The following is a description of a gene set: Human Gene Set: REACTOME_NEURONAL_SYSTEM Neuronal System species: Homo sapiens, and this is the list of marker genes: GLRA2, KCNMB1, EPB41L2, GABRR3, KCNJ14, SYT7, GNGT2, HTR3C, KCNK7, GABRA4, GABRB1, SLITRK2, CHRNA1, ADCY2 (NCBI Gene Id 254679), CHRNA3, GNB3, AKAP5, TUBB8B, RTN3, DNAJC5, KCNH3, LRRTM3, BCHE, GRIA4, EPB41L5, DLGAP4, CAMK1, GNG10, SLITRK5, GABRR1, KCND2, KCNV1, CAMK2A, RIMS1, GLRA1 (glycine receptor alpha 1), TSPAN7, GNAI3, GNG3, SYN1, GABRA2, KCNJ12, PRKAR1B, GNGT1 (G protein subunit gamma transducin 1), SHARPIN, GRIP2, KCNA5, GRIN2C, DLG1, CACNA1E, PRKAA2, CACNG3, KCNJ4, GABRB3, ABCC8, MAPK3, NRXN2, KCNJ6, EPB41, ACHE, LRRTM2, SLC1A7, MAOA, GJC1, KCNF1, ADCY1, PPFIBP2, LRRC4B, ADCY6, PPFIBP1, AP2B1, KCNK9, PLCB2, NLGN3, CAMK2B, CAMK2D, MAPT, PRKCG, BEGAIN, TUBA3C, SLC6A13, TSPOAP1, CAMKK2, NPTN, HCN1, SLC32A1, KCNH4, SYN2, SLC18A3, KCNA4, CHRNA7, KCNAB2 (NCBI Gene Id 8514), NSF, KCNA10, TUBB3, ERBB4, APBA1, GRIN2A (glutamate ionotropic receptor NMDA type subunit 2A), NBEA, RAC1, KCND1, GJD2, SHANK2 (NCBI Gene Id 654128), KCNB2, AP2M1, GRIN2D, HOMER3, KCNH5, NAAA, KCNJ10 (potassium inwardly rectifying channel subfamily J member 10), HCN3, AP2A1, GLUL, KCND3, TUBA3D, KCNH6, AP2S1, KCNQ1, SYT10, GNB4, DLG4, KIF17, CAMKK1, PPFIA4, GABBR1, KCNJ11, NLGN2, KCNMB4 (NCBI Gene Id 27345), AP2A2, COMT, GIT1, GLS2, RASGRF1, ARL6IP5, GNB2, PTPRF, NRXN3 (neurexin 3), TUBA1A, GLRB, KCNK1, EPB41L1, LRRC51, CASK, GRIK4, CACNB2, MAPK1, GABRA5, CHRNE, KCNAB3, GRIN3A, STX1A, RPS6KA2, SYN3 (synapsin III), SLC22A2, GABRG2, TUBA4A, KCNA7, KCNS1, GNG13, ADCY4, PRKAG2, ALDH2, DBNL (drebrin like), SLC6A1, KCNJ1, CACNG4 (calcium voltage-gated channel auxiliary subunit gamma 4), GABRB2, KCNK3, CACNG2, ALDH5A1, ADCY8, CHRNA2, CHRNB3, KCNJ8, CHRNB4, MDM2, CHRNA5, GJA10, KCNJ2, CALM1, DLG2, GRIN1, SLC6A3, DLGAP1, SLC1A2, SLITRK4, GAD1, KCNG1, KCNK4, PTPRD, KCNQ3, TUBA8, KCNH1, KCNN2, KCNC3, RPS6KA6, NRXN1, SLC1A6, KCNJ5, SYT1, DLG3, CACNA1B, PRKAA1, PRKAG1, SYT12, SHANK1, KCNB1, HOMER2, HOMER1, NCALD, VAMP2, KCNG4, KCNMB3, KCNC4, FLOT2, GNG8, KCNH8, SNAP25, KCNQ4, ABCC9, FLOT1 (flotillin 1), CHRNG, CREB1, LRRC7, NRAS, CHRNA6, LRRTM1, UNC13B, GNG7, SLC38A1, NLGN4X, PRKCB, HTR3A, SLC38A2, CACNA1A (NCBI Gene Id 773), NEFL, SLITRK6, PLCB1, GNG5, GABRA3, KCNJ9, KCNC1, SLC22A1, KCNK10, IL1RAPL1, GRIA1, KRAS, KCNK16, CHRNB2, GRIP1, RPS6KA1, HRAS, TUBA1B, PANX2, GABRG3, ADCY5, PTPRS, KCNMA1, HTR3B, ARHGEF7, GRM5, GABBR2, KCNAB1, RPS6KA3, KCNH7, SLC5A7, ADCY9, PICK1, KCNG3, KCNG2, KCNN4, TUBB4A, KCNQ2, PDPK1, SIPA1L1, ARHGEF9, LRTOMT, ABAT, DLGAP3, CHRND, APBA2 (NCBI Gene Id 9029), GRIK3, KCNJ16, TUBA3E, HCN4, TUBB2A, GABRQ, LRRTM4 (leucine rich repeat transmembrane neuronal 4), PRKACA, IL1RAP, MYO6, CAMK4, SLC6A11, PPM1F, KCNA3, LIN7C, GABRA6, PPM1E, KCNH2, TUBB8, SLC6A12 (NCBI Gene Id 6539), SLC1A3, HTR3E, SYT2, CACNA2D2, KPNA2, HTR3D, TUBB2B, GNAI1, GABRA1, PRKAB2, RAB3A, KCNJ3, KCNV2, GNG12, KCNK2, TUBB1, TUBB4B, TUBA4B, DLGAP2, CHAT, KCNK13, CACNB4, GNAI2, KCNMB2, CAMK2G, CHRNA4, GLRA3, LRFN2, KCNS3, KCNN3, ACTN2, GNB5, SLC1A1, GABRR2, EPB41L3, PDLIM5, GRIN3B, GRIA3, RASGRF2, GRIK5, SLC17A7, PANX1, NRG1 (neuregulin 1), GAD2, PRKAB1, KCNK6 (NCBI Gene Id 9424), HSPA8, PPFIA1, ADCY7, GNG11, KCNS2, LIN7A, TUBA1C, KCNA6, GRIK1, LIN7B, TUBAL3, GRIN2B, SLITRK1, HCN2, PRKAR2B, CACNB1, CPLX1, PRKX, GLS, NTRK3, CHRNA9, GNG2, GNAL, CACNG8, KCNN1, CACNB3, PPFIA2, PLCB3, SRC, PRKAR2A, PRKACG, NLGN4Y, PRKACB, GNG4, KCNA2, PPFIA3, STXBP1, KCNC2, NLGN1, KCNK17 (potassium two pore domain channel subfamily K member 17), PRKAG3, NRGN, APBA3, GRIK2, SLC6A4, LRFN3, GRM1, KCNK18, GNB1, GNAT3, LRFN4, ADCY3, KCNQ5, CACNA2D3, PRKAR1A, KCNJ15, GRIA2, LRFN1, IL1RAPL2, SLITRK3, SYT9, SLC18A2, KCNA1, TUBB6, PRKCA